The following is a description of a gene set: The process of directing proteins towards the vacuole, usually using signals contained within the protein. species: Homo sapiens Human Gene Set: GOBP_PROTEIN_TARGETING_TO_VACUOLE, and this is the list of marker genes: SORT1, VPS37D, MON1B, VPS53, BECN1, NDP, AP3B1, VPS4A, SORL1, ZFYVE16, IRGM, GNPTAB, ATG14, WASH3P, MON1A, AP3M1, AP3D1, HSPA8, SQSTM1, AP4M1, VPS54, VPS37C, VPS8, GGA3, GNPTG, VPS37B, RAB7A, SNX16, PIK3R4, VPS13C, NEDD4, GCC2, NCOA4, LAPTM5, SMURF1, M6PR, VPS37A, NAGPA, VPS13A, PIK3C3, VPS13D, LAMP2, SCARB2, CLU, HGS, VPS41